Given this list of marker genes AZIN1, UBE2W, WWP1, FBXO33, ADAM10, AHR, MED13L, ADD1, MTDH, FAM210B (NCBI Gene Id 81895), DACT1, RNF19A, DAPK1, LRRC57, KRAS, PCDHGB7, GRIK2, PCDH9, CLK1 (NCBI Gene Id 1195), RAP2C, TRAPPC10 (trafficking protein particle complex subunit 10), DLGAP4, CRY1, RANBP2, E2F3, SBNO2, FAM76B, BNC2, YTHDF3, HOXA11, PCDHGA4, DPP4, HNRNPA2B1, PCDHGC4, RAB7A, TPP2, STT3A, PCDHGB4, MAF, PCDHGA8, KCNH7, RNF182, KLF13, PCDH8, OTX2, ILRUN, KLHL5, LGSN, KCNMB2, NLGN1, AZI2, SCN5A, PDP1, CPEB2, PCDHGB3, PCDHGA2, SH3KBP1, NRIP1, KANK4, SYN2, BICD2, CLCN5, KCNB1, SLC7A11, PLEKHA6 (pleckstrin homology domain containing A6), BTG3, CXCL12 (C-X-C motif chemokine ligand 12), BMAL1, GAN, NTF3, ANK2, PCDHGA5, SERTAD2, PCDHGA6, FHIP2A, MAP2K6, UBL3, STK4, MBNL2, BACH2, RBM26, RAB21, USP6, VASH2 (vasohibin 2), ARID2, TOPORS, PIP4P2 (NCBI Gene Id 55529), CDK19, PCDHGC3, AFF2, IRS2, DOC2A, ATP11A, BPNT2, TBX3, PURA, SERBP1, ARMC8, MYH3, GPM6A, VLDLR, DOCK9, TMSB4XP8, BRD1, PCDHGA1, FBXW11, PRKAB2, AMMECR1, DNAJB11, CAP1, PCDHGA3, SMURF1, HECTD2, IGF1R, SH3GL2, PDS5A, TOR1AIP1, SRSF10, RAB2B, KBTBD12, HECW2, NCOA2, SF3B1, SOX11, GLCE, FMR1, WRNIP1, MEF2C, EPHB2, NBEA, STIMATE, PTBP1 (polypyrimidine tract binding protein 1), KCTD15, BRINP1, SP3, APBB2, PRKAR2B, WDFY3, DYRK2, TCEAL1, DYNLT3, CACNA1C, PCDHGC5, RAB11FIP2, KLF5, FBXL17 (F-box and leucine rich repeat protein 17), WTAP, UBE2Z, PCDHGB1, PCDHGA7, NAV1, KPNA3, ZNF711, PHF3 (NCBI Gene Id 23469), ELL2, FBXO28, SS18 (NCBI Gene Id 6760), RICTOR, PFN2, GPHN, PCDHGB6, ZCCHC2, MPPED2, RORB, ZFHX4, PCDHGA12, CEP97, DAGLA, SIRT1, GDF6, COLEC12, ATOSA, ETV1, BCL2, DNM3, DCAF5, PCDHGB5 (protocadherin gamma subfamily B, 5), ELF2, DTNA, NHS, XYLT2, TSEN15, ATXN3, UNC5A, BCL11A (BCL11 transcription factor A), SAMTOR, PELI1, RAVER2, SOCS5, PCDHGA10, PCDHGB2, CNTN4, PCDHGA11, FOXJ3, TMSB4X, RSRP1, ING3, GNAI1, VEZF1, GABRB3, APPBP2, EPHA4, AGAP1, PCDHGA9, AUTS2, KCTD9, RNGTT, LYST, MPC1, CASP4, PAPPA, here is a description of the gene set: species: Homo sapiens Human Gene Set: ATATGCA_MIR448 Genes having at least one occurence of the motif ATATGCA in their 3' untranslated region. The motif represents putative target (that is, seed match) of human mature miRNA hsa-miR-448 (v7.1 miRBase).